Given this list of marker genes GRB2, ATP6V0C, SOS2, MAPK3, ARAF, EGFR, NRAS, MAPK1, BRAF, KRAS, RAF1, MAP2K1, MAP2K2, HRAS, SOS1, here is a description of the gene set: Pathway Definition from KEGG: E5 -| V-ATPase -| EGFR -> GRB2 -> SOS -> RAS -> RAF -> MEK -> ERK HPV E5 to EGFR-RAS-ERK signaling pathway. Pathway ID: N00367. Pathway type: Pathogen. Pathway class: nt06166 Human papillomavirus (HPV). Human Gene Set: KEGG_MEDICUS_PATHOGEN_HPV_E5_TO_EGFR_RAS_ERK_SIGNALING_PATHWAY studied in species Homo sapiens